The following is a description of a gene set: studied in species Mus musculus Mouse Gene Set: GOBP_REGULATION_OF_SYNAPTIC_VESICLE_PRIMING Any process that modulates the frequency, rate or extent of synaptic vesicle priming. Synaptic vesicle priming is the formation of SNARE-containing complexes, bringing synaptic vesicle membrane and plasma membranes into close proximity and thereby facilitating membrane fusion., and this is the list of marker genes: Napa, Rab3a, Napb, Unc13a, Stx1b, Stxbp1, Syngr3, Osbpl2, Syp, Unc13b, Brsk1, Stxbp5, Rims1, Stx1a, Rab3gap1 (NCBI Gene Id 69346)